Given this list of marker genes TYRP1, CEP170, YOD1, TRIP12, HIPK1, MRFAP1, ASB15, TOX, DICER1, RLF, SMAD7, ZCCHC24, FGFR1, TRIM44, KLHL9, ESYT3, ATP2B2, MYH10 (NCBI Gene Id 4628), NPTXR, MLLT10, STRBP, NSD3, ABHD2, TPM3, SMURF2, TRIM3, RND3, HDAC5, PCDHA10, NAT8L, MAPK1 (mitogen-activated protein kinase 1), API5, AMOT (angiomotin), SH3GL2, MAP2K5, PDGFD, PDLIM5, CSNK1A1, SHOX2, TAF5, DYRK1A, DPP10, RAP1A, PAPOLA, PCDHA6, ZC3H12B (NCBI Gene Id 340554), TEAD1, PURA, PRDM8, RFWD3, MAP2K1, ZBTB44, MSL2, SPRY3, CNBP, PHLPP2, SRGAP2, JPH1, CDK6, MRPL27, STEAP4, PCMT1, PDCD4, QKI, NRXN3, IGSF3, AMMECR1L, PAFAH1B1, CALML4, PCDHA13, ITPK1, APBB2, LRP8, GRIN2B, ENSG00000286546, ID2, SOSTDC1, WDFY3 (NCBI Gene Id 23001), DCAF7, NCOA2, FCHSD2, AFF4, GRID1, FAM107B, FYTTD1, OTUD4, LTN1, EIF4E, SRPK2, UBE2Q2, ITM2C (integral membrane protein 2C), ZNF800, NKAPD1, DNAJC13, SLC8A3, GRM5, NSG1, SORCS1 (sortilin related VPS10 domain containing receptor 1), PCDHA1, CBFA2T2, CAPZA1, SCOC, PRR3, CELF3, LRP1B (LDL receptor related protein 1B), PCDHA2, ACBD3, SELENOI, XIAP, ITCH, GRIA3, KLHL35, NSMCE3 (NSE3 homolog, SMC5-SMC6 complex component), RAI2, TARDBP, MLEC, BICD2, LRRC75A, PAIP2, ARMCX6, PPM1E, SYT7, B4GALT1, PCDHA4, ANKS1B, MACROD2, PPP1R1B, BMI1, ABHD4, SLC25A3, GNAO1, PCYT1B, TRAK2, PRUNE2, ARHGEF9, NF2, BTG1, TRPS1, DEK, SLC17A6, CMPK1 (NCBI Gene Id 51727), ZNF423, DCP2, FNBP4, SMG7, GNL1, NR4A3, CSNK1A1L, NAA30, CREBBP, PICALM (NCBI Gene Id 8301), RUNX2, CRISPLD1, NFATC3, PCDHAC2, ARK2C, TCF12, ABCC12, MEF2C, NT5DC3, ETF1, GSKIP, TIPARP, DCX, FAM91A1, SP4, RBM12, GALNT7, RHOT1, BMPR2, OGT, NUP58 (nucleoporin 58), C5orf15, BTRC, BACH1, OTOGL, COL6A3, GCG, KAT2B, DLX1, FBXO34, PHC2, DHX40, KANSL1, QSER1, CSNK1G3, SEPTIN12, RAB6A, PPM1B, FOXJ2 (NCBI Gene Id 55810), CLCN5, BCOR, BICRAL, PCDHA11, MTDH, PTPN4, PTGFRN, APPL1, TNRC6B, ESR1, NCEH1, PCDHA5, SNAP23, RAP2C, MTM1, POU4F2, PIGA, GPRASP2, SKIL, SEC62, GIGYF2, FOXN3, FNTB, BMP2K, ZBTB4, LYN, TDG, DIP2B, ATP2B1, SYT5, MAML1, PCDHA12, BRWD1, CCDC178, HNRNPU, TRAPPC8, GPHN, PCDHA9, CNPPD1, POU3F1, SOX21, GPM6A, RAP2A, LHX6, BCL11B, CA12, ZNF410, CHP1 (calcineurin like EF-hand protein 1), TGFBR3 (transforming growth factor beta receptor 3), PUM2 (NCBI Gene Id 23369), MBNL1, ZFY, METTL5, STXBP3, IGF2BP3, PDZRN3, TJP1, ARPP21, FRK, HOXC8, PCDHAC1, MYEOV, CCND3, CPSF7 (cleavage and polyadenylation specific factor 7), BCORP1, PCDHA7, SLITRK4, RUNX3, DPYSL3, ADD3, ARMC1, PRTFDC1, PCDH11X, FBXL17 (F-box and leucine rich repeat protein 17), IRX2, RNF126, DIRAS2, ID2B, KCNA6, MIER3, GATAD2B, JADE2, JPH3, GPAM, DCLK1, GTF2H1, METAP2, PRKG1, MTMR9, RC3H1, ACVR1, SRSF1, CYTH3, RNF111, KCNIP2, SLC4A10, PCDHA8, TFEB, DLX6, NKRF, HIVEP2, PCDH11Y, AMPH, TMEM263, APC, PLCB1, EFNA3, VEGFD, ZNRF2, AP2M1, TMEM196, EGR4, C5orf24, MTPN, EFNB2, PCDHA3, DAG1, CTDSPL2, SET, MTCH1, BCL9 (NCBI Gene Id 607), CADM3, AGTR2, IFIT1, STAU1, SYBU, STYX, MBNL2, KIF1B, ANTXR2, IQCH, SOX13, PRKCB, YPEL2, PLXNA2, SH3PXD2A, LUZP1, SOX11, TRIB2, SIN3A, E2F1, TRA2B, FOXG1, here is a description of the gene set: Human Gene Set: TGCTTTG_MIR330 Genes having at least one occurence of the motif TGCTTTG in their 3' untranslated region. The motif represents putative target (that is, seed match) of human mature miRNA hsa-miR-330 (v7.1 miRBase). studied in species Homo sapiens